Given this list of marker genes H2-T5, H2-M10.4, H2-K1, Tap2, Cd1d2, H2-M10.3, H2-M10.2, Ap3b1, Cd1d1, Abcc1, H2-Q10, H2-T22, H2-M2, H2-M3, H2-M1, H2-T15, H2-T24, Ulbp1, H2-T3, H2-Q7, H2-Q2, Raet1d, Azgp1, H2-M5, H2-M10.5 (histocompatibility 2, M region locus 10.5), H2-Q4, H2-M11, H60b, H2-D1, H2-T23, Raet1e, H2-M10.1, Ap3d1, H2-Q1, H60c, H2-T13, H2-M9, B2m, 2410137M14Rik, H2-M10.6, H2-Q6, here is a description of the gene set: Mouse Gene Set: GOBP_ANTIGEN_PROCESSING_AND_PRESENTATION_VIA_MHC_CLASS_IB The process in which an antigen-presenting cell expresses antigen (peptide or lipid) on its cell surface in association with an MHC class Ib protein complex. Class Ib here refers to non-classical class I molecules, such as those of the CD1 or HLA-E gene families. species: Mus musculus